The following is a description of a gene set: Human Gene Set: GOBP_NEGATIVE_REGULATION_OF_PLATELET_ACTIVATION Any process that decreases the rate or frequency of platelet activation. Platelet activation is a series of progressive, overlapping events triggered by exposure of the platelets to subendothelial tissue. studied in species Homo sapiens, and this is the list of marker genes: CEACAM1, TMX1, CD9, PRKG1, THBD, UBASH3B, SERPINE2, PDGFB, F2, APOE, PDGFA, SH2B3, PRKCD, C1QTNF1, PDGFRA, ALOX12, ADAMTS18, NOS3 (NCBI Gene Id 4846)